The following is a description of a gene set: Human Gene Set: GOMF_TOLL_LIKE_RECEPTOR_BINDING studied in species Homo sapiens Binding to a Toll-like protein, a pattern recognition receptor that binds pattern motifs from a variety of microbial sources to initiate an innate immune response., and this is the list of marker genes: CD36, S100A8, SYK, UNC93B1, TLR10, LY96, TIRAP, MYD88, TLR2, DAB2IP, TLR6, TOLLIP, TLR1, S100A9